Given this list of marker genes Grin2b, Grik2, Slc1a7, Gria2, Grin2a, Slc17a7, Grik1, here is a description of the gene set: studied in species Mus musculus Enables the transmembrane transfer of an ion by a channel that opens when glutamate is bound by the channel complex or one of its constituent parts on the extracellular side of the plasma membrane. Mouse Gene Set: GOMF_EXTRACELLULARLY_GLUTAMATE_GATED_ION_CHANNEL_ACTIVITY